The following is a description of a gene set: part of: Xenobiotics species: Homo sapiens Reactome Pathway: CYP2E1 reactions CYP2E1 can metabolize and activate a large number of solvents and industrial monomers as well as drugs. This quality of CYP2E1 may make it an important determinant of human susceptibility to the toxic effects of industrial and environmental chemicals. Typical CYP2E1 substrates include acetaminophen, benzene, CCl4, halothane, ethanol and vinyl chloride. CYP2E1 contributes to oxidative stress by producing oxidising species called reactive oxygen species (ROS) which can lead to damage to mitochondria, DNA and initiate lipid peroxidation or even cell death., and this is the list of marker genes: CYP2S1, CYP2B6 (cytochrome P450 family 2 subfamily B member 6), CYP2C8, CYP2D6, CYP2C19 (cytochrome P450 family 2 subfamily C member 19), CYP2C9, CYP2A13, CYP2A7, CYP2F1, CYP2E1, CYP2A6